The following is a description of a gene set: studied in species Mus musculus Mouse Gene Set: GOMF_SULFUR_AMINO_ACID_TRANSMEMBRANE_TRANSPORTER_ACTIVITY Enables the transfer of sulfur amino acids from one side of a membrane to the other. Sulphur amino acids contain sulfur in the form of cystine, methionine or their derivatives., and this is the list of marker genes: Slc7a9, Slc43a2, Slc7a11, Slc1a2, Ctns, Slc25a12, Slc1a4, Slc25a13, Mfsd12, Slc1a1